The following is a description of a gene set: The killing by an organism of a cell in another organism by means of the rupture of cell membranes and the loss of cytoplasm. Mouse Gene Set: GOBP_CYTOLYSIS_IN_ANOTHER_ORGANISM species: Mus musculus, and this is the list of marker genes: Igtp, Gbp2b, Gbp5, Ccl28, Gbp7, Gbp3 (NCBI Gene Id 99898), Gbp2 (NCBI Gene Id 14469)